Given this list of marker genes GAST, RPS6KA1, GNB2, PRKCH, DGKK, OPN4, NMUR1, LPAR3, GPRC6A, GHSR, PRKCD (NCBI Gene Id 5580), GNB4, GNG5, CASR, EDNRA, LPAR5, P2RY11, EGFR, F2R, CCL23, XCL2, LTB4R, ITPR2, AVP, PROK2 (NCBI Gene Id 60675), FFAR3, GRB2, GCGR, MAPK3, PMCH, P2RY6, NMB, P2RY1, HBEGF, KISS1, GNG11, RPS6KA2, HTR2A, GNAQ, GNG12, DAGLA, GNRH2, CHRM5, CYSLTR1, PIK3R2, GPR4, PLCB3, APP, MCHR1, DGKQ, UTS2R, GRK2, LPAR1, FFAR1, MAPK7, P2RY2, PTGER1, DGKB, F2RL3, HRAS, RGS16, MMP3, KNG1, ADRA1B, DGKG (NCBI Gene Id 1608), BTK, GNRHR, AVPR1B, DGKZ, UTS2B, LTB4R2, EDNRB, PRKCE, CYSLTR2, GCG, TRIO, OXT, GNA11, XCL1, GRP, GPR17, NTSR1, PIK3CA, HRH1, HCRTR1, EDN3, GHRL, SAA1, GPR132, ANXA1, AGTR1, GNB5, NPFF, F2RL1, GNRH1, PLCB4, LPAR2, RGSL1, RGS21, NMUR2, TRPC6, KISS1R, TACR2, BDKRB1, CCKAR, QRFPR, EDN1, NMBR, MCHR2, ADRA1D, PRKCQ, NTSR2, GNG10, GNG13, AVPR1A, DGKA, PLCB2, GNGT1, GNB1, RGS13, PIK3R3, HTR2C, DGKI, CHRM3, OXTR, F2, NPFFR1, RGS4, FFAR4, GNG8, MLNR, ARHGEF25, CREB1, CHRM1, RASGRP2, TAC1, RGS17, TRPC7, ITPR1, PIK3R1, DGKH, HCRT, CCK, PROKR1, DAGLB, DGKD, GRK5, MLN, NTS (NCBI Gene Id 96646), GPR143, NMU, RGS5, F2RL2, GPR39, LPAR4, ADRA1A, MGLL, QRFP, LPAR6, MAPK1, GNG7, TRHR, NPS, HCRTR2, SOS1, ABHD6, XCR1, PTAFR, GRM5, ITPR3, GNG4, KALRN, RPS6KA3, GNB3, NMS, DGKE, RGS18, GNGT2, GRPR, BRS3, RGS19, RGS1, GRM1, NPSR1, PROKR2, P2RY10, GNG3, PTGFR, GPR65, RGS3, NRAS, GNG2, RASGRP1, CCKBR, GNA15, AGT, TRPC3, EDN2, PROK1, TRH, GPR68, RGS2, PLCB1, TAC3, ABHD12, BDKRB2, UTS2, FPR2, PRKCA, TACR1, TACR3, HTR2B, KRAS, TBXA2R (thromboxane A2 receptor), NPFFR2, FFAR2, GNA14, here is a description of the gene set: studied in species Homo sapiens Human Gene Set: REACTOME_G_ALPHA_Q_SIGNALLING_EVENTS G alpha (q) signalling events